Given this list of marker genes Col15a1, Mmp14, A2m, Mmp17, Eln, Cma1, Col13a1, Fbn2, Klk1b4, Tmprss6, Col26a1, Adam15, Capn6, Col4a4, Spp1, Fn1, Mmp13, Mmp7, Timp2, Capn3, Htra1, Tpsb2 (tryptase beta 2), Col18a1 (collagen, type XVIII, alpha 1), Ctsb, Mmp8, Klk1b24, BC051665, Ctss, Col6a6, Adamts4, Prss1, Col3a1, Col6a2, Adam8, Klk1b16, Col8a1 (collagen, type VIII, alpha 1), Klk1b1, Col11a1, Phykpl, Try10, Col4a6, Col4a1, Klk1b26, Col25a1, Cd44, Prss3l (serine protease 3 like), Capn12, Col19a1, Capn1, Klk1b21, Ctsg, Mmp10, Mmp16, Capn10, Cast, Col5a3, Col6a1, Prss1l, Col1a1 (collagen, type I, alpha 1), Try5, Optc, Mmp24, Col6a5, Col8a2, Klkb1, Capn8, Adamts5, Col11a2, Spock3, Mmp1a, Furin, Elane, Fbn1, Mmp3, Col6a3, Prss3, Klk7, Bsg, Col4a2, Col4a3, Capn2, Klk1b5, Klk1b27, Klk1b9, Klk1b11, Ctsl, Scube1, Ctrb1, Bcan, Capns1, Try4, Capn15, Klk1b3, Prss2, Capn5 (calpain 5), Mmp9, Dcn (decorin), Mmp2, Capns2, Ctsd, Mmp11 (NCBI Gene Id 17385), Col10a1, Capn7, Col5a2, Plg, Col12a1, Timp1, Col2a1, Ctsk, Mmp12, Capn9 (calpain 9), Mmp20, Adam10 (NCBI Gene Id 67314), Acan, Col5a1, Col1a2, Capn11, Mmp19, Scube3, Mmp25, Col7a1, Capn13, Nid1, Klk1b8, Mmp15, Col4a5, Klk1, Klk1b22 (NCBI Gene Id 13646), here is a description of the gene set: studied in species Mus musculus Mouse Gene Set: REACTOME_DEGRADATION_OF_THE_EXTRACELLULAR_MATRIX Degradation of the extracellular matrix